Given this list of marker genes KPNB1, HSPB1, HRAS, TMSB10, SMARCD3, RAC1, CCND2, CUX1, ISG15, HSF1, GDF1, CDK10, GSTP1, MCL1, TNPO2, PRDX2, here is a description of the gene set: Wilms' tumor (WT), one of the most common pediatric solid cancers, arises in the developing kidney as a result of genetic and epigenetic changes that lead to the abnormal proliferation and differentiation of the metanephric blastema. As activation of signal transducers and activators of transcription (STATs) plays an important role in the maintenance/growth and differentiation of the metanephric blastema, and constitutively activated STATs facilitate neoplastic behaviors of a variety of cancers, we hypothesized that dysregulation of STAT signaling may also contribute to WT pathogenesis. Accordingly, we evaluated STAT phosphorylation patterns in tumors and found that STAT1 was constitutively phosphorylated on serine 727 (S727) in 19 of 21 primary WT samples and two WT cell lines. An inactivating mutation of S727 to alanine reduced colony formation of WT cells in soft agar by more than 80% and induced apoptosis under conditions of growth stress. S727-phosphorylated STAT1 provided apoptotic resistance for WT cells via upregulation of expression of the heat-shock protein (HSP)27 and antiapoptotic protein myeloid cell leukemia (MCL)-1. The kinase responsible for STAT1 S727 phosphorylation in WT cells was identified based upon the use of selective inhibitors as protein kinase CK2, not p38, MAP-kinase kinase (MEK)1/2, phosphatidylinositol 3'-kinase, protein kinase C or Ca/calmodulin-dependent protein kinase II (CaMKII). The inhibition of CK2 blocked the anchorage-independent growth of WT cells and induced apoptosis under conditions of growth stress. Our findings suggest that serine-phosphorylated STAT1, as a downstream target of protein kinase CK2, plays a critical role in the pathogenesis of WT and possibly other neoplasms with similar STAT1 phosphorylation patterns. Human Gene Set: TIMOFEEVA_GROWTH_STRESS_VIA_STAT1_DN from publication Timofeeva OA, Plisov S, Evseev AA, Peng S, Jose-Kampfner M, Lovvorn HN, Dome JS, Perantoni AO (PMID 16799645) studied in species Homo sapiens Genes down-regulated in SK-NEP-1 cells (Wilm's tumor ) stably expressing inactivated forms of STAT1 under growth stress (hypoxia or nutritional deprivation).